Given this list of marker genes PDGFA, SEMA3F, NRG1, SEMA4F, SEMA3G, NTN1, ITGAV, SEMA4D, SEMA3D, ROBO1, SEMA3A, SLIT1, SLIT2, DPP4, SEMA5A, SEMA3B, NRP2, SEMA4G, SEMA3E, NRG3 (neuregulin 3), SEMA6C, EFNA5, WNT5A, UNC5C, LGR6, SEMA6A, SEMA7A, SEMA4B, SLIT3, RHOA, RYK, SEMA5B, SEMA3C, APOA1 (apolipoprotein A1), SEMA6B, PLXNA4, SEMA4C, PLXNA3, ROBO2, SEMA6D, SEMA4A, ITGB3, FLRT2, FLRT3, EPHA7, here is a description of the gene set: The directed movement of a motile cell or organism towards a lower concentration of a chemical. Human Gene Set: GOBP_NEGATIVE_CHEMOTAXIS species: Homo sapiens